The following is a description of a gene set: Human Gene Set: HP_CYTOCHROME_C_OXIDASE_NEGATIVE_MUSCLE_FIBERS An abnormally reduced activity of the enzyme cytochrome C oxidase in muscle tissue. studied in species Homo sapiens Cytochrome C oxidase-negative muscle fibers, and this is the list of marker genes: DGUOK, TRMU, BRAT1, AARS2, POLG2, MT-TE, COA3, RRM2B, MRPL44, COA8, SLC25A42, TACO1, TYMP, GTPBP3, ETHE1, MIEF2, RRM1, POLG, TWNK, PUS1, NDUFA4, MT-TN, LRPPRC, SURF1, YARS2, TRMT10C, TK2, RNASEH1, FBXL4, COX10, SLC25A4, TRMT5, COX6B1, COX6A2, SCO2